The following is a description of a gene set: Human Gene Set: GOMF_LONG_CHAIN_FATTY_ACID_BINDING species: Homo sapiens Binding to a long-chain fatty acid. A long-chain fatty acid has an aliphatic tail containing 13 to 22 carbons., and this is the list of marker genes: PRR7, SCP2, PPARG, FABP4, S100A9, FABP9, OXER1, FABP2, PPARD, TMEM175, FABP3, UCP1, GPR31, ALOX5AP, S100A8, STX3